The following is a description of a gene set: species: Mus musculus Mouse Gene Set: MIR_205_5P Genes predicted to be targets of miRBase v22 microRNA mmu_miR_205_5p in miRDB v6.0 with MirTarget v4 prediction scores > 80 (high confidence targets). from publication Chen Y, Wang X (PMID 31504780), and this is the list of marker genes: Rcbtb1, Abhd17b, E2f5, Ntng1, Clock, Serpina12, Kdm4b, Senp7, Sdha, Slc35a5, Irf2bpl, Cadm1, Mmd, Ctps2, Amot, Cdh11 (cadherin 11), Car8, Tsc22d1, Adgrl2, Eva1c, Msi2, Trp53bp2, Vps50, Frk, Bet1l, Map3k13, Or5m3b, Gpc6, Pramel55, Rock2, Mical2, Tgfa, Lmod3, Srsf10, B3gnt6, Herc3, Nf1, Ssbp3, Lhfpl2, Habp4, P2ry1, Afdn, Kat2b (NCBI Gene Id 320956), Akna, Coa6, Slc24a2, Psd3, Zhx1, Krtap24-1, Abcd1, Ndufa4, Rad17, Sh2d4a, Ublcp1, Ccdc93, Csf1, Lin9, Mosmo, Rora, Sbf2, Rab11fip1, Lrp1, Mfng, Ralyl, Kif7, Med1, Chn1, Vasn, Med12l, Dsc1, Zfp800, Prkce, Cltc, Rnf41, Phf3, Wnk3, Mgrn1, Lims2, Fbxo22, Ezr (ezrin), Crebrf, Hs3st1, Nhsl2, Nufip2 (nuclear FMR1 interacting protein 2), Lrrk2, Tln2, Magi2, 1110032F04Rik, Tmem45a2, Golm2, Zeb2, Hsf5, Lpar1, Eif1a, Pde7a, Pramel42, Fut8, Errfi1, Rlig1, Slc35a1, Slc7a6, Esrrg, Selenot, Slc35f5, Slc35b3, Cldn11, Pde3b, Epb41 (erythrocyte membrane protein band 4.1), Sertad2, Zeb1, Tm9sf2, Traf3, Dpm1, Rbm47, Dsc3, Sema7a, Septin4, Cpeb2, Ptprj, Fam168a, Pramel57, Pramel48, Reln, Axin2, Taok1, Rtn3, Zfp775, Zfp646, Etnk1, Nfat5, Gpx3, Invs, Traf3ip1, Zmym4, Unc5c, Lamc1, Tead1, Ereg, Cpsf6, Dusp7, Zfp715, Ddx52, Ccnj, Strbp, Spag6l, Mdh1b, Vegfa, Necap1, Wdr33, Plcb1, Lum, Slc19a2, Phc2, Sorbs1, Septin12, Vti1b, Cep55, Ptprm, Aak1, Adamts9, Gpm6a (glycoprotein m6a), Rnf157 (NCBI Gene Id 69919), Epb41l4b, Erbb4, Lrch3, Dnm3, Heg1, Runx2, Cdk19, Tmem68, Pcsk9, 4921517D22Rik, Naa25, Spmip9, Mtfr1l, Calu, Cgnl1, Slc31a1, Zcchc14, Kdm1b, Pax9, Acsl1, Smad1, Satb2, Btbd3